Given this list of marker genes FNIP2, CENPB, MINDY4 (NCBI Gene Id 84182), CDS1, PGM1 (phosphoglucomutase 1), TP53RK, PPP2R2A, GNL3, VEGFB, AGPAT5, NRP1, SMYD5, TSR1, MAP2K2, STX12, PELP1, ELL2, MECR, AK3, CTSD, CAPNS1, YARS1, ERAP1, MLF2, FAF1, ITK, CPPED1, DCUN1D3, FURIN, FTO, MRPL37, SNX12, CTNND1, TMEM87B, SRM (spermidine synthase), PLEC, NRROS, IL7R, PTGR1, ANPEP, RING1, AOAH, PLGRKT, PTGR2, SLC35F6, WBP11, DNAJB11, NENF, CHMP1A, FAM120A, MRPS2, GSTM1, SRGAP2, ACBD6, EDN1, BRI3, SRP72, GFUS, NIBAN2, CHCHD4, STUB1, DES, INHBA, AIMP2, ARL4A, TFEC, GAS6, ABCE1, IKBKE, EVL, RAD51B, CENPI, DCSTAMP, RBPJ, PEA15, SLC12A7, OXCT1, FAM216A, FAM162A, C12orf43, TCTN3, PELO, MRTFB, COMTD1, CHDH, LRP12, FOXJ1, PLSCR3, FIZ1, LRMDA, SNAPC2 (small nuclear RNA activating complex polypeptide 2), DCTN2, BTBD8 (NCBI Gene Id 284697), RIPK3, MRPS7, SEMA3C, SLC25A39, TMTC3, NOP9, C19orf47, TBL1X, PARD6G, SULF1, NIPA1, TNFRSF9, CFB, ANGEL1, PLK3, SNX9, GIPC1, ATP6V0D1, SMN1, NUCB2, IMMT, ARHGAP10, FAM110B, KCTD17, KATNA1, CC2D1A, SYCE2, RRP15, ENTPD7, C3orf70, MND1, GCLM, SYN1, FADS3, PA2G4, RNPEP, CAD, LONRF3, HRAS, MMP13, CNDP2, GPR171, RCBTB1, CNOT9, TFPI2, TMEM143, U2SURP, TMEM106C, CCDC22, INO80E, GEMIN8, BST1, HIVEP3, TUBB, SNX7, UAP1L1, FUBP3, FBXL15, ENO1, PSMD9, DNAJC6, PDCD5, SLC25A1 (NCBI Gene Id 6576), FLYWCH1, TACC2, LAMC1 (laminin subunit gamma 1), NHP2, PLEKHN1, CTSV, IL1A, HSPA9, SPATA6 (NCBI Gene Id 54558), TCF25, ZFPM1, TIMM22, LAMA4, DDHD2, MAN1C1, ACTN4, SP2, HLA-C, PSMD1, MIEF2, MYO5A, DRG2, SNRPD1, RARRES2, GASK1B, FBXW8, SPRY4, TPP1, TUBB4B, CTSZ, DSEL, RUVBL1, WDSUB1, HSP90B1, KIF2A, TMEM237, MED15, CENPT, CCL7, CLN5, NAGPA, EIF1AY, RBM19, CREB5, here is a description of the gene set: studied in species Homo sapiens Genes down-regulated in CD8A CD8B versus B1 B lymphocytes. from publication Yamagata T, Benoist C, Mathis D (PMID 16623764) Human Gene Set: GSE3039_ALPHABETA_CD8_TCELL_VS_B1_BCELL_DN Three innate (B1-B, NKT, CD8aaT cells) and adaptive (B2-B, CD4T, CD8abT cells) cell-types were sorted by FACS. Three biological replicates for NKT, CD4T, CD8aaT, CD8abT cells and two biological replicates for B1 and B2 cells were generated and the expression profiles were determined using Affymetrix Mu74Av2 chip. Comparisons between the sample groups allow the identification of genes differentially expressed between the innate and adaptive cell-types.